The following is a description of a gene set: Human Gene Set: GOBP_CRANIAL_SUTURE_MORPHOGENESIS The process in which any suture between cranial bones is generated and organized. species: Homo sapiens, and this is the list of marker genes: TWIST1, INSIG2, MSX2, GLI3, TGFB1, INSIG1, FGF4, BMP4